The following is a description of a gene set: studied in species Mus musculus Any apoptotic process that is involved in blood vessel morphogenesis. Mouse Gene Set: GOBP_APOPTOTIC_PROCESS_INVOLVED_IN_BLOOD_VESSEL_MORPHOGENESIS, and this is the list of marker genes: Bax, Lrp5, Spi1, Wnt7b, Bak1, Lef1